The following is a description of a gene set: Any process that stops, prevents, or reduces the frequency, rate, or extent of an inflammatory response to an antigenic stimulus. Mouse Gene Set: GOBP_NEGATIVE_REGULATION_OF_INFLAMMATORY_RESPONSE_TO_ANTIGENIC_STIMULUS studied in species Mus musculus, and this is the list of marker genes: Trem2, Psma1, Npy, Nod2, Adcyap1, Spn, Nlrp6, Npy5r, Il20rb, Mkrn2, Il12b, Selenos, Gpr17, Fcgr2b, Psmb4, Gpx1, Gpx2, Il10